Given this list of marker genes SLC25A23, ZNF708, SP8, ZSWIM9, C4orf19, HMCN1, DCLRE1C, GALNT10, NSFL1C, EYS, CCDC92, TPBGL, WBP1L, TMED2, POLQ, HSP90B1, RFC3, AP3S1 (adaptor related protein complex 3 subunit sigma 1), KDSR, ILDR2, PGK1, PIP5K1A, TMEM139, C11orf58, NECTIN2, KDM4C, KRTAP17-1, C5orf15, NOVA1, DACT1, HEY2, here is a description of the gene set: from publication Chen Y, Wang X (PMID 31504780) studied in species Homo sapiens Genes predicted to be targets of miRBase v22 microRNA hsa-miR-769-3p in miRDB v6.0 with MirTarget v4 prediction scores > 80 (high confidence targets). Human Gene Set: MIR769_3P